The following is a description of a gene set: studied in species Homo sapiens Human Gene Set: GOBP_MONOCARBOXYLIC_ACID_CATABOLIC_PROCESS The chemical reactions and pathways resulting in the breakdown of monocarboxylic acids, any organic acid containing one carboxyl (-COOH) group., and this is the list of marker genes: ACOT7, ACAA1, LDHC, ETFB, AKT2, CROT, LEP, CRAT, AGXT, ETFBKMT, FAAH, PCK2, ABCD2 (ATP binding cassette subfamily D member 2), MCEE, CYP4F2, CYP4F12, SULT2A1, PEX5, ABHD2, DECR1, HADHA, ENSG00000293349, TWIST1, LPIN2, ACOT8, ACOX3, CPT2, CYP2W1, AUH, SLC25A17, ACOXL, CYP4F3, ACAA2, ACADM, PEX7, ACAD11 (NCBI Gene Id 84129), ETFA, ACAD10, ILVBL, ECHS1, GLYATL2, ECH1, AKT1, MTLN, ACADS, ADTRP, ECHDC2, IRS2, LDHD, MFSD2A, ABCD4, LONP2, AKR1A1, SLC16A3, AGXT2, AIG1, MCAT, PCCA, SLC27A4, PLIN5, ACACB, ABHD3, PHYH (NCBI Gene Id 8024), CYP26C1, ABCD1, DLAT, HADH, CYP26B1, EHHADH, ADIPOQ, ECHDC1, LDHA, SLC27A2, ECI2, LPIN3, PCCB, HADHB, ECI1, FAH, ETFDH, ACADL, AMACR, HOGA1, ABCD3, PCK1, ACBD5, CYP4A11, IRS1, ACAT1, ABHD1, PEX13, IVD, PEX2, SLC16A1, AKR1D1, BDH2, HSD17B4 (hydroxysteroid 17-beta dehydrogenase 4), ALDH1L2, SCP2, CRYL1, NUDT8, PPARA, GCDH, TYSND1, CPT1B, PLA2G15, XYLB, CPT1A, HAO1, ABCB11, ACOX1, SESN2, HSD17B10, HACL1 (NCBI Gene Id 26061), CYP26A1, ACOX2, DECR2, SORD, DCXR, NUDT19, MLYCD, NUDT7, LPIN1, PPARD, ACADVL